The following is a description of a gene set: Human Gene Set: GSE360_HIGH_VS_LOW_DOSE_B_MALAYI_DC_UP Genes up-regulated in comparison of dendritic cells (DC) exposed to 50 worms/well B. malayi versus those exposed to 5 worms/well B. malayi. studied in species Homo sapiens from publication Chaussabel D, Semnani RT, McDowell MA, Sacks D, Sher A, Nutman TB (PMID 12663451) Monocyte-derived dendritic cells (DC) and macrophages (MΦ) generated in vitro from the same individual blood donors were exposed to five different pathogens, and gene expression profiles were assessed by microarray analysis. Responses to Mycobacterium tuberculosis and to phylogenetically distinct protozoan (Leishmania major, L. donovani, Toxoplasma gondii) and helminth (Brugia malayi) parasites were examined, each of which produces chronic infections in humans yet vary considerably in the nature of the immune responses they trigger., and this is the list of marker genes: ARL4D, ZC3H14, MAN2C1 (mannosidase alpha class 2C member 1), STK39, TRA2B, CTNNB1, ORC2, TNFSF4, TPD52L2, SSUH2, FAM131A, H2BC12, ACIN1, MAU2, BTG3, JTB, CARD8, IL2RA, NDUFC1, SHROOM2, THUMPD1, ZRSR2 (zinc finger CCCH-type, RNA binding motif and serine/arginine rich 2), SV2A, CACNA1D, GPR65, OVOL2, MAGEA11, EPHX2, TMED3, TXNL1, SIAH2, KIF14, DUSP7, SEM1, KCNA3, SERPINB3, ATR, PSMA4, AKR1B10, CYP2D6, CTH, IPO7, COPS7A, ATP1B3, UBXN8, AATF, TK1, ATXN2L, MICAL2, ZNF516 (NCBI Gene Id 9658), P4HA1, MKLN1, N4BP1, SHOX2, LARP4B, ADCY9, AIMP2, BIRC2, GLCE, STRAP (serine/threonine kinase receptor associated protein), RAB33A, MSMB, CLNS1A, PRMT1, FAM216A, PRKCI, BAAT, RNF44, DUT, ILVBL, DNAJC2, ATAD2B, HGS, MISP, GCH1, PGAM1, PDIA4, FAM20B, ACSL4, ZRSR2P1, SPIDR, MARF1, KIAA0232, SERPINE1, MEGF9, LILRA2, ACO1, OSTF1, GNA15, TMEM115, LRIT1, NPRL3, ACTA2, MED1, H1-10, CALB1, BICD1, ACTC1, DNAH7, MAPK9, ATP6V1G2, ATP4B, TSC22D1, LTBP1, NFKBIE, CDYL, PRMT2, DHX38, PDE4B, TBC1D8, IFNA5, CT62, HOXD9, DMD, SLC25A36, PLOD3 (procollagen-lysine,2-oxoglutarate 5-dioxygenase 3), CAMTA2, STXBP2, HMGA2, PEG10, GPS2, CHRNE, SDR39U1, GBE1, ITGB5, TUBG1, CROT, FAM171A1, SHB, KIAA0319, TCEA1, SLC22A4, TBC1D22A, CDS1, CDKN2A, SORCS3, TRIP6, SLC37A4, PNLIP, BTBD8, STARD13 (NCBI Gene Id 90627), HOXB2 (homeobox B2), CTSO, ATRX, SCFD1, RAB9A, ADGRV1 (adhesion G protein-coupled receptor V1), RALA, FERMT2, ZCCHC24, BAIAP2, ADD1, UBAC1, RABIF, SYCP1, CHGB, DUSP11, TET3, PDE6H (phosphodiesterase 6H), ZSWIM8, PFKFB1, SLC12A5, CCIN, NAA80, DCTN2, GRIN2C, ENDOU, ALDH1B1, MAPK10, ADAM12 (ADAM metallopeptidase domain 12), ANAPC13, COMP, FILIP1L, RRAGA, COPS2 (COP9 signalosome subunit 2), GLDC, KLHL21, PPP4C, SERTAD2, GLO1, RLN2, ADNP, CELF2, NPY1R, CD2AP, PPBPP2, BNIP3L, SCG2, AP4S1, AP4E1, GADD45A, USP7, VAMP7, ABCC3, HERC2P3 (NCBI Gene Id 8921), CTSB, SS18L1, PHF8